The following is a description of a gene set: A process that is carried out at the cellular level which results in the assembly, arrangement of constituent parts, or disassembly of PML bodies, a class of nuclear body; they react against SP100 auto-antibodies (PML = promyelocytic leukemia). Mouse Gene Set: GOBP_PML_BODY_ORGANIZATION species: Mus musculus, and this is the list of marker genes: Pml, Habp4, Ets1, Sumo1, Serbp1, Agap3, Daxx